Given this list of marker genes SMURF1, PSMD3, WNT5A, RYK, PSMD12, SCRIB (NCBI Gene Id 23513), RAC1, PSMD6, AP2B1, PRKCA, ROR1, PSMC6, AP2A2, FZD8, PSMD2, PSMA7, WNT5B, PSMB4, PSMC3, PSMB1, SEM1, PSMC4, PSMA6, PSMD11, FZD7, PSMB6, FZD6 (NCBI Gene Id 8323), DVL3, ROR2, WNT4, VANGL2, RPS27A, PSMA3, UBA52, PSMD13, ADRM1, RAC3, FZD5, PSMA1, PARD6A, PSMB3, PSMB2, DVL2 (NCBI Gene Id 1856), PSMD8, CLTC, PSMC2, ARRB2, PSMD7, PSMA4, PSMB7, UBB, WNT1, CLTA, PSMC1, AP2M1, RHOA, RAC2, FZD3, CLTB, DVL1, DAAM1, FZD4, PSMB5, PSMA2, PSMD14, PSMD1, PRKCB, UBC, FZD2, AP2S1, FZD1, WNT11, PRKCG, PFN1, AP2A1, PSMA5, PSMC5, PRICKLE1, SMURF2, here is a description of the gene set: The planar cell polarity (PCP) pathway controls the establishment of polarity within the plane of a sheet of cells. PCP was initially characterized in Drosophila, where it controls the arrangement of hair bristles and photoreceptors in the eye. In vertebrates, PCP regulates convergent extension (CE, a process by which a tissue narrows along one axis and lengthens along a perpendicular one), closure of the neural tube, hair orientation and inner ear development, among others. Studies in Drosophila identified a core group of PCP genes including Frizzled (Fz), Flamingo (Fmi), Van Gogh (Vang), Dishevelled (Dsh), Prickle (Pk) and Diego (Dgo), whose products become asymmetrically localized in the cell upon initiation of PCP (reviewed Maung and Jenny, 2011). Subsequent studies in vertebrates have shown that many of these PCP genes are conserved. <br>Unlike in Drosophila, where the upstream signal for the PCP pathway has not been defined, in vertebrates, a number of so-called 'non-canonical' WNTs have been shown to have roles in PCP processes. WNT5B and WNT11 are both required for CE during gastrulation, and WNT5A physically and genetically interacts with VANGL2 in the inner ear and the developing limb bud. WNT ligand can be bound by one of a number of FZD receptors or the single pass transmembrane proteins RYK or ROR, depending on context. Although the downstream pathway is not well established, vertebrate PCP signaling appears to work at least in part through DVL, DAAM1 and small GTPases to remodel the actin cytoskeleton. species: Homo sapiens Reactome Pathway: PCP/CE pathway part of: Beta-catenin independent WNT signaling